Given this list of marker genes LINC01554, LINC00482, DIO2, GPC6, AGR2, DHDH, LAIR1, RALGPS1, LGALS2, USP43, BCO2, BTNL9, JAKMIP2, ZBED3-AS1, ARHGAP20, DHRS9, JRK, BEST2, MRC1, PDE8B, PLAAT2, SOD2-OT1, GRK4, MPV17L, NR3C2, MARCO, A1BG, RPGRIP1, ADARB2, MUCL1, VSIG1, here is a description of the gene set: Human Gene Set: MEBARKI_HCC_PROGENITOR_WNT_DN_CTNNB1_DEPENDENT Transcriptome of human HepaRG hepatocellular carcinoma liver progenitors in responses to a WNT3A-enriched microenvironment and dissection of pathways dependent on _-catenin and/or blocked by the SFRP-like Wnt inhibitor FZD8_CRD. Methods: Liver progenitor cells were incubated in a WNT-enriched microenvironment for 72hrs (200 ng/ml mouse recombinant purified Wnt3A from R&D Systems). Gene pathways dependent on downstream _-catenin were studied by _-catenin knockdown with specific siRNA. Gene pathways blocked by extracellular SFRP-like Wnt inhibitors were studied by co-incubating cells with recombinant purified FZD8_CRD (300 ng/ml, from R&D Systems). Independent culture experiments performed in triplicate include untreated cells or cells incubated with scrambled siRNA or with _-catenin-specific siRNA or with FZD8_CRD, alone or in combination with Wnt3A. studied in species Homo sapiens from publication Mebarki S, Désert R, Sulpice L, Sicard M, Desille M, Canal F, Dubois-Pot Schneider H, Bergeat D, Turlin B, Bellaud P, Lavergne E, Le Guével R, Corlu A, Perret C, Coulouarn C, Clément B, Musso O (PMID 27191501)